Given this list of marker genes Spg7, Mcub, Psen2, Ucp2, Akt1, Afg3l2, Vdac1, here is a description of the gene set: Any process that modulates the frequency, rate or extent of calcium import into the mitochondrion. Mouse Gene Set: GOBP_REGULATION_OF_CALCIUM_IMPORT_INTO_THE_MITOCHONDRION species: Mus musculus